The following is a description of a gene set: species: Homo sapiens Human Gene Set: GOBP_PROTEASOME_ASSEMBLY The aggregation, arrangement and bonding together of a mature, active proteasome complex., and this is the list of marker genes: ECPAS, OTUD6B, PSMD9, PSMD5, PSMG4 (proteasome assembly chaperone 4), UBLCP1, SEM1, PSMG1, PSMD11, PSMD10, PSMG3, PSMG2, PSMB5, POMP, ADRM1